Given this list of marker genes Atp1a1, Atp1a2, Nr3c1, Sult2b1, Gper1, Esr2, here is a description of the gene set: Mouse Gene Set: GOMF_STEROID_HORMONE_BINDING studied in species Mus musculus Binding to a steroid hormone.